The following is a description of a gene set: species: Homo sapiens Human Gene Set: GOBP_REGULATION_OF_HYDROLASE_ACTIVITY Any process that modulates the frequency, rate or extent of hydrolase activity, the catalysis of the hydrolysis of various bonds, e.g. C-O, C-N, C-C, phosphoric anhydride bonds, etc. Hydrolase is the systematic name for any enzyme of EC class 3., and this is the list of marker genes: PSAP, AGRN, EPHA4, SGSM3, RECK, PRSS22, CR1, RHOC, EFNA5, SERPINB4, RAB3GAP2, RIC1, RSU1, RACK1, PDE3A, EZH2, TBC1D7, BCAR3, RPS3, RGS7, PLXNB3, URI1, PLXNB2, TBC1D20, DAB2IP, PLIN5, ADAP1, RALGAPB, PIP5K1A, KLRK1, OAS1, ADCYAP1, DOCK9, RAPGEF1, RCN3, RASA4, TBC1D30, RAB11FIP2, RAB3GAP1, AKT1 (NCBI Gene Id 207), RAPGEF3, PRTN3, EPHB3, HMGB1, ARHGEF16, ABCE1, SPOCK3, LRCH1, MIR138-1, SERPINB13, BVES (blood vessel epicardial substance), TIAM1, PRELID1, NDEL1 (nudE neurodevelopment protein 1 like 1), RIPOR1, LRRK2, PROM2, RASIP1, VSIR, RALGAPA1, SERPINB9 (serpin family B member 9), NET1, USP6NL, CHP1, ATP13A2, SEMG2 (NCBI Gene Id 6407), GPSM1, ARL2, RAP1GAP, DFFA, EVI5L, FGD4, UBXN1, SPOCK2, FGFR2, GPR137B, SYDE2, FGFR1 (NCBI Gene Id 84151), TIMP2, OAS3, CCDC125, MET, PNLIP, MTMR9, EVI5, TBC1D15, DOCK11, GZMA, TBC1D2, HSPA1A, APC2, RAPGEF6, SERPINA5, PRKG1, CRB2, DVL3, RALGAPA2, GBA3, ECT2, EPHA5, DOCK10, SNX13, LIMS1, SEMA4D, F2RL1, SVBP, FETUB, RALBP1, SRGAP2, MIA2 (NCBI Gene Id 91818), S100A10, DOCK8, PRKCD, BCR, VAV2, RGS16, ITGB1BP1, GAPDH, PPP1R17, PLXNB1, PCNA, NTRK1, RTN4R, KLRC4-KLRK1, GNB5, RGS10, FGD5, CAMK2A, ATP5IF1, NF1, MBP, SERPINB8, RAP1A, FGD3 (FYVE, RhoGEF and PH domain containing 3), CHP2, TANK, SIRT1, NEIL1, ITGB1, VCP, SH3BP1, ECM1, ARHGAP11A, FGD2, EPHA3, ARHGAP42, RHOA, THY1, RDX, ARHGAP44, ARFGEF1, GPLD1, WRN, RCC2, ODAM, CRK, MMUT, SERPINB3, RANGAP1, ASAP3, USP17L2, RIPOR2, PTK2, SEMG1, RGS6, SNX18, GRN, NTRK2, ARAP1, EPHA2, GNAT1, SNX9, PLA2G5, EPM2A, SOD1, EPPIN, RAPGEF2, NGEF, FGFR3, VAV3, ABR, RHOG, ARHGEF5, STMN1, RRP1B, VAV1, NPM1, ITGA6, SCRIB, A2ML1, SGSM2, CDK5RAP3, RABGAP1, BMP2, PSENEN, RGS8, TIMP1, ARHGEF7, RGS1, SERPINB1, ZC3H15, FGD1, LARS1, FICD, SIPA1L1, TBC1D10B, MTSS2, FGD6 (NCBI Gene Id 55785), ARHGAP11B, CORO1C, TSC1, TGM2, SYDE1, RASGRP1, ALS2, SH3BP4, RASGRP2, RGP1, TMED2